Given this list of marker genes Rfx8, Gm26788, Gm17970, Gm18799, Gm26145, Cfc1, Gm29128 (NCBI Gene Id 102634543), Gm25096, AI597479, Gpr45, Gm28175, Mitd1, Gm8176, Creg2, Inpp4a, A930005N03Rik, D930019O06Rik, Eef1a1-ps2, Cracdl, Gm6428, 1110002O04Rik, Eif5b, Gm28419, Ankrd23, Gm23453, Gm5266, Cnnm3, Gm29228, Neurl3, Zap70, Gm3617, Bend6, Gm16152, Rab23, Lyg1, Coa5, Alyreffm3, Gm33280, Mrpl30, Arid5a, Prss40, AA619741, Gm25634, 4933424G06Rik, Actr1b, Gm35801, 1700001G17Rik, Gm5099, Gm24826, 4930568A12Rik, Gm9458, 1700074A21Rik, Amer3, Gm33533, Dnaaf6rt, Mir6896, Gm2987, 4930470B04Rik (NCBI Gene Id 75807), Ptp4a1, Gm29260, Ccdc115, Mrps9, Gm9915, Rpl31, Tgfbrap1, Rev1, 4930420N18Rik, Cox5b, Semp2l1, 4930456G14Rik, Aff3, Gm20428, Gm28645 (NCBI Gene Id 100505265), Il18r1, 4930439A04Rik, Alyreffm1, Gm15455, Lyg2, Slc9a4, 4930594C11Rik, Mir6898, Npas2, Gm19863, Gm7893, Gm29730, Lonrf2, Prim2, Gm37435, Fam178b (NCBI Gene Id 71849), F830112A20Rik, Gm5267, Gm6621, Txndc9, Gm23126, Gm3052, Gm18828, Bag2 (NCBI Gene Id 74827), Gm28417, Vwa3b, 4930556I23Rik, Nms, Gm5973, Lgsn, 2610300A13Rik, Rnf149, Il1rl1, Gm33222, Imp4, Prss39, Cnnm4, Dalir, Gm8210, Gm8022, Gm23032, Gm9839, Smim39, Alyreffm2, Unc50 (unc-50 homolog), Tbc1d8, Gm17813, Rpl12-ps1, Gm16894, Mfsd9, Gm7114, n-R5s211, Lman2l, Gm16150, Gm25792, Gm37047, Gm34727, Gm4850, Gm3646, 4930403P22Rik, Ptpn18, Pantr1 (NCBI Gene Id 66297), Gm28782, Gm7910, Tmem131, Snord89, Gm23792, 4930535G08Rik, Il1r2, Pdcl3, Tsga10, Mir5103, Ankrd39, Plekhb2, Pou3f3, Gm37915, Lipt1, Khdrbs2, Gm4785, Gm24732, 1700066B17Rik, Gm8009, Gm24901, Fam168b, Uggt1, Tmem182, Zfp451, Chst10, Gm23722, Gm37233, 4930448I06Rik, Fhl2, Il1r1, Map4k4, Mir6349, Gm5100, Gm7933, Gm37020, Cnga3, Dst, Hs6st1, Pantr2, Fer1l5 (fer-1 like family member 5), D430040D24Rik, Gm19680, Slc9a2, Gm19430, Mir6897, 8430432A02Rik, Kansl3 (NCBI Gene Id 98416), Mgat4a, Gm20646, Il18rap, Il1rl2, Gm25814, 1700101I19Rik, Arhgef4, Cnot11, Sema4c, here is a description of the gene set: studied in species Mus musculus Mouse Gene Set: chr1B